The following is a description of a gene set: Any process that modulates the frequency, rate, or extent of mast cell activation as part of an immune response. Human Gene Set: GOBP_REGULATION_OF_MAST_CELL_ACTIVATION_INVOLVED_IN_IMMUNE_RESPONSE studied in species Homo sapiens, and this is the list of marker genes: FER, SPHK2, ENPP3 (ectonucleotide pyrophosphatase/phosphodiesterase 3), CD300A, PTPN6